Given this list of marker genes CNNM2, CSPP1, C2CD3, FH, GCDH, KIAA0586, here is a description of the gene set: studied in species Homo sapiens Human Gene Set: HP_OPEN_OPERCULUM Underdevelopment of the operculum. Open operculum